Given this list of marker genes MIB1, PARP14, STK40, SERPINB9, BCKDHB, NLGN1, GOSR1, LIN9, BCL2L15, SFXN1, GABRG2, C6orf120, CCL13, RIPK2, FER, PFKP, BASP1, ESD, ABCB4, MTDH (metadherin), PHYHD1, ZBTB7A, NOL7, CITED2, STAT5A, NHERF1, WBP2, PROKR1, PUM3, DPM1, IFIT2, CDKN2A, HK2, PKP4, TRMT112, DSCAM, ADHFE1, SRXN1, RNF128, HOXA9, MAP3K6, CACNA2D3, TIPARP, NFKBIA (NFKB inhibitor alpha), TBC1D13, GUCD1, HTRA2, DIS3, COL5A1, OAS2, DHPS, DGAT2, CYP39A1, NSUN2, VEGFC, YKT6, UBXN8, LYN, TRAF3IP2, HTR2B, LBP, LTA, NECTIN2, CPD, KYAT3, SQSTM1, SP110, ZBP1, SLC2A1, ZNF605, RAD23A (RAD23 homolog A, nucleotide excision repair protein), TIMMDC1, SPTLC2, NFKB1, HSP90AA1, CYP2D6, P2RX1, UBE2M, DAB1, TDRD7, ELOC, PSMA4, NAE1, CASP4, POLB, TWIST1, SNRNP27, ATP6V1C2, CCT7, NME6, IRS1, PIGB, COL9A1, TMEM243, ZAN, LRRC59, CHCHD4, CTTN, MRAS, CCL2, FABP3, PPP1CB, C9orf72, ZNG1B, ADAMTS5, MAFF, TAGLN2, GSR, SERPINE1, MC3R, UCN, CTPS1, ELL2, CCT8, BST2, SMYD1, ACTN1, USP25, LHX2, ZNRF1, PLEKHA3, CCDC71L, LIG3, SHC1, PDZK1IP1, FBXW11, SCRG1, CTTNBP2NL, SH3TC1, TMEM199, COPG1, CDKN1A, SLC6A12, EVA1C, NET1, REPS1, AHR, PI4K2A, POP7, DGCR8, AMBN, VCL, EXOC7, HSD17B12, USO1, MITF, DHX58, NUB1, METTL6, MYD88, DDHD1, CBS, GRK2, DUSP16, TXNL1, ADPRS, NR5A2 (nuclear receptor subfamily 5 group A member 2), PRMT7, C1orf52, SEC24D, HOXB9, HINFP, UBA1, EMD, GLMP, DMKN, RASA2, SLFN12L, INO80E, GLIS1 (NCBI Gene Id 148979), PA2G4, VCAN, TIMP1, HELZ2, SYNPO2, OPA3, RILPL1, EBI3, ANKRD26 (NCBI Gene Id 22852), DNAJC1, IRX3, LEPR, MTMR14, ASNS, ST3GAL5, LZTFL1, NMD3, SLC28A2, IFNAR1, FCRL1, GHRH, NAA35, PPIG (peptidylprolyl isomerase G), CCRL2, LUC7L (LUC7 like), IL15RA, SRP54, FSCN1, here is a description of the gene set: mouse primary BMDCs were stimulated with tlr ligands and gene expression changes were profiled on Affymetrix arrays studied in species Homo sapiens Genes down-regulated in comparison of control dendritic cells (DC) at 12 h versus those stimulated with Gardiquimod (TLR7 agonist) at 12 h. from publication Amit I, Garber M, Chevrier N, Leite AP, Donner Y, Eisenhaure T, Guttman M, Grenier JK, Li W, Zuk O, Schubert LA, Birditt B, Shay T, Goren A, Zhang X, Smith Z, Deering R, McDonald RC, Cabili M, Bernstein BE, Rinn JL, Meissner A, Root DE, Hacohen N, Regev A (PMID 19729616) Human Gene Set: GSE17721_CTRL_VS_GARDIQUIMOD_12H_BMDC_DN